The following is a description of a gene set: from publication Yamanaka R, Arao T, Yajima N, Tsuchiya N, Homma J, Tanaka R, Sano M, Oide A, Sekijima M, Nishio K (PMID 16652150) Genes whose expression most strongly and consistently associated with the short term survival of patients with high grade glioma tumors. Better understanding of the underlying biology of malignant gliomas is critical for the development of early detection strategies and new therapeutics. This study aimed to define genes associated with survival. We investigated whether genes coupled with a class prediction model could be used to define subgroups of high-grade gliomas in a more objective manner than standard pathology. RNAs from 29 malignant gliomas were analysed using Agilent microarrays. We identified genes whose expression was most strongly and consistently related to patient survival based on univariate proportional hazards models. In six out of genes, changes in gene expression were validated by quantitative real-time PCR. After adjusting for clinical covariates based on a multivariate analysis, we finally obtained a statistical significance level for DDR1 (discoidin domain receptor family, member 1), DYRK3 (dual-specificity tyrosine-(Y)-phosphorylation-regulated kinase 3) and KSP37 (Ksp37 protein). In independent samples, it was confirmed that DDR1 protein expression was also correlated to the prognosis of glioma patients detected by immunohistochemical staining. Furthermore, we analysed the efficacy of the short interfering RNA (siRNA)-mediated inhibition of DDR1 mRNA synthesis in glioma cell lines. Cell proliferation and invasion were significantly suppressed by siRNA against DDR1. Thus, DDR1 can be a novel molecular target of therapy as well as an important predictive marker for survival in patients with glioma. Our method was effective at classifying high-grade gliomas objectively, and provided a more accurate predictor of prognosis than histological grading. Human Gene Set: YAMANAKA_GLIOBLASTOMA_SURVIVAL_DN species: Homo sapiens, and this is the list of marker genes: DDR1, ALCAM, IRF9, IFT88, PDCD4, ITGB2 (integrin subunit beta 2), TMEM218, NRBP2